The following is a description of a gene set: studied in species Mus musculus This event has been computationally inferred from an event that has been demonstrated in another species.<p>The inference is based on the homology mapping from PANTHER. Briefly, reactions for which all involved PhysicalEntities (in input, output and catalyst) have a mapped orthologue/paralogue (for complexes at least 75% of components must have a mapping) are inferred to the other species. part of: Transport of vitamins, nucleosides, and related molecules electronically inferred by orthology from the curated human pathway Reactome Pathway: Transport of nucleotide sugars, and this is the list of marker genes: Slc35b2, Slc35d1, Slc35d2, Slc35c1